The following is a description of a gene set: species: Homo sapiens Description of conditions in which not all individuals with a given genotype exhibit the disease. Penetrance is the proportion that develop disease given a lifespan of 80 years. Human Gene Set: HP_TYPIFIED_BY_INCOMPLETE_PENETRANCE Typified by incomplete penetrance, and this is the list of marker genes: USP48, LRP5, DSTYK, DEPDC5, NPRL2, CTNNB1, MT-CO3, GREB1L, DLX5, PTCH1, NRIP1, ERBB3, CLCN2, FH, SHH, MT-ND4L, PRRT2, INAVA, DDX41, GABRB3, FGFR1, THAP1, ANO3, TM4SF20, NF2, PRPF31, GATA5, LZTR1, FGF23, CHRNA2, PROKR2, MFN2, TICAM1, SUFU, CACNB4, RPS29, RBM12, UCHL1, GLI2, ATL1, RORB, MSH6, SMARCC1, PRKCG, TRPV4, COL4A1, POT1, PKD2, FMR1, ELP1, RANBP2, PRPF8, VWF, LRRK2, NLRP12, KLF13, PARN, MT-ND2, TBK1, SGCE, WNT10B, SIX1, TLR3, MT-ND1, FLCN, TOR1A, TGFBR1, SMARCE1, BRCA2, MT-CYB, NTN1, OTULIN, ATXN10, OPA1, GABRG2 (NCBI Gene Id 2566), TENM4, ELOVL4, MT-ND5, ATP1A3, JAG1, TMEM151A, TTN, KIF1B, SDHB, HNRNPDL (NCBI Gene Id 9987), TERT, COL4A2, GJC2, EPHB4, CRELD1, SMAD6, CACNA1S, DCC, PTEN, MT-ATP6, VMA21, SLC12A5, PTCH2, CHRNA7, RELN, RAD51, CAV1, GJA5 (gap junction protein alpha 5), TERC, PITX1, CACNA1A (calcium voltage-gated channel subunit alpha1 A), CDH23, PRCC, IFIH1, PROK2, KMT2B, EYA1, NR5A1, SCN4A, GRIN2A, IKZF1, MT-ND6, GPR161, CHRNA4, GJB1, HCN1, LRSAM1, BMPR2, KIF11, ATP1A2, NRL, SIX3, STAT1, SCN1B (sodium voltage-gated channel beta subunit 1), RTEL1, MET, DLST, CILK1, CTLA4, NPRL3, PDGFB, SMARCB1, CFC1, CPOX, MT-ND4, PAX2, GJA8, MN1, KRIT1, DCX, KIF5A, ACTN4, MNX1, FOXE3, SMAD9, SLC2A1